Given this list of marker genes PISD, GDPD3, CCL13, ERRFI1, SCAMP1, PTGS2, CCND2, DLD, TUBA8, MAP2K4, DNAJA1, PROCR, RAB18 (NCBI Gene Id 22931), GRIN2B, ARIH2, CH25H, SELP, DAZAP1, SLC30A4, BTG3, SERPINH1, LHX9, IL10, COPS4, PADI2, ILF3, TOP1, ITM2A, RBM18, CAVIN1, BHLHE40, LTA, GRIA4, CXCL10, CCL7, DNAJB6, PIAS2, NAP1L4, ZFP36L1, SLC39A4, TANK, PDGFA, INHBC, SLC25A15, ANGPTL2, SNCB, SLC30A3, PIM1, DSTN, IRF1, SEC11C, B4GALT3, ATP6V1H, ID1, ETF1, GPCPD1, CDK8, STK40, RIOK3, HSP90AA1, GADD45G, CYB561, ACSL4, IL1B, MOB1B, TBRG4, NPY1R, VCL, SMAD6, NMD3, ABRACL, PPP1R15A, SERPINB2, TRA2B, MADCAM1, RCAN1 (NCBI Gene Id 1827), EXOSC5, CDKN1A, PLAC9, MFSD14A, LPAR1, KCNJ11, HOXD8, MAP3K8, UPP1, PTPRF, TIMP3, SCAND1, RAB3IL1, MARCHF7, DUSP1, MYL4, NFKBIZ, NF1, CXCL2, KLHDC2, MDM2, PDCL3, IL1RN, EI24, SOCS3, JUNB, IL4R, TAX1BP1, ZNF644, TXNRD1, EGR2, SGK1, CTPS1, GADD45B, STT3B, UGCG, ANK1, MEMO1, IL1A, PPIC, SEPTIN2, SOCS2, DDX3Y, PGM2, LIN7C, SLC20A1, EEIG1, CD14 (CD14 molecule), BGN, SPG21, ZNF703, IGF2BP1, CD86, NFKBIA, DDX50, USF1 (upstream transcription factor 1), YTHDC1, EEA1, IER2, PELI1, ZFP62, GJA1, SERPINE1, DDX5, MMP12, BIRC3, HMOX1, AAK1, ETS2, LRRC58, IFRD1, CDKN2B, ICAM1, MT2A, CR1L, IER3, COL6A1, RAD51B (NCBI Gene Id 5890), FAM83H, FN1, TNFSF9, TMC6, BTG2, CXCL9, RELB, EGR1, CYRIB, RAB12, SOX7, MYC, KCMF1, TMEM70, UGDH, CPEB2, NR4A1, DUSP2, MMP14, MIDN, DNAAF10, GSTM3, CD83, LAPTM4A, IST1, HLA-E, PLAUR, GTF2E2 (NCBI Gene Id 2961), PLAT, GPC4, SLC25A17, EHD1, SLN, EFNA1, ATP6AP1, FBLN2, PHLDA1, SRGN, F2RL3, GTPBP4, KCTD12, NDEL1, CXCL3, MCOLN2, TMEM41B, FOS, here is a description of the gene set: from publication Toker A, Engelbert D, Garg G, Polansky JK, Floess S, Miyao T, Baron U, Düber S, Geffers R, Giehr P, Schallenberg S, Kretschmer K, Olek S, Walter J, Weiss S, Hori S, Hamann A, Huehn J (PMID 23420886) Human Gene Set: GSE42021_CD24HI_TREG_VS_CD24HI_TCONV_THYMUS_DN We investigated at which stage of maturation commitment to a stable Foxp3-expressing phenotype takes place. We assessed stability of Foxp3 expression in thymic Foxp3+ Treg subsets of different maturity, defined by CD24 expression. Next we compared gene expression profiles of Foxp3+ Treg subsets (+) of different maturity (24lo, 24int, 24hi) and could identify a set of genes that were specifically up or downregulated in Foxp3+ Tregs, but not in Foxp3- conventional T cells, in a maturation-dependent manner. species: Homo sapiens Genes down-regulated in CD42 high cells from thymus: T reg versus T conv.